The following is a description of a gene set: Mouse Gene Set: GOBP_PYRIMIDINE_RIBONUCLEOTIDE_BIOSYNTHETIC_PROCESS The chemical reactions and pathways resulting in the formation of a pyrimidine ribonucleotide, a compound consisting of nucleoside (a pyrimidine base linked to a ribose sugar) esterified with a phosphate group at either the 3' or 5'-hydroxyl group of the sugar. studied in species Mus musculus, and this is the list of marker genes: Uprt, Cmpk1, Nme4, Upp1, Ak9, Ctps1, Nme3, Ctps2, Uckl1, Uck2, Nme2, Umps, Dhodh, Nme1 (NCBI Gene Id 18102), Dck, Upp2, Nme7, Cad, Nme5, Cda, Uck1, Nme6